The following is a description of a gene set: species: Homo sapiens Genes down-regulated in comparison of untreated CD4 T cells versus CD4 T cells treated with leukocyte costimulatory blockade antibodies. To elucidate the gene expression “footprint” of antigenically challenged T-cells which had been treated with anti-LFA-1, CTLA4Ig, anti-CD40-ligand antibodies, we performed microarray gene expression analysis comparing the expression profile of costimulatory blockade treated and untreated responder T-cells. from publication Pearl JI, Lee AS, Leveson-Gower DB, Sun N, Ghosh Z, Lan F, Ransohoff J, Negrin RS, Davis MM, Wu JC (PMID 21362570) Human Gene Set: GSE26669_CTRL_VS_COSTIM_BLOCK_MLR_CD4_TCELL_DN, and this is the list of marker genes: ST8SIA1, ARHGAP24, ATL1, FCRLA, MOSMO, RELL1, SCD, PTK2B, PRG4, TLE4, GGA2, ROGDI, ACP5, ABHD8, USP33, PRPS2, MBD4, ARF6, MTPAP, EOLA1, CROCC, CTU1, CABLES2, PRKCI, RC3H2, HMCES, RAP1B, ADD3, PDLIM7, RHOT1, CCDC71, SEMA3D, COQ8A, FAM3C, TES, ZBTB4, RIT1, EVI2B, HIBCH, MXI1, JUNB, ZNF799, PTGFRN, KIF1C, ADCY9, AXDND1, OARD1, SMC5, FPR3, LRRC42, PHF8, MAN1C1, TSC22D3, ATP6V0D1, EPC1, SIK3, CCN1, PDE2A, IQSEC1, MTIF3, LEF1, H2BC18, WDR26, SAA4, MBD1, CSNK1E, MTA3, RSPRY1, NINJ1, MTNAP1, FILIP1L, SGPL1, BMPR2, SETX, ERLIN2, NAA16, PEX12, ZNF771, TMC5, YPEL3, CCDC82, METTL27, DDX31, HAO2, ASNSD1, GID4 (NCBI Gene Id 79018), MAP3K5, CDR2, CCNY, CCR6, TTBK2, IER5, CYTH4, FOXJ2, GABRR2, TTC36, COLEC12, PCYOX1, SSMEM1, TMEM74B, CLCA1, RFFL, MZB1, RETREG3, BCL11A, CHIC2, ST8SIA6, MEX3B, RPS6KB1, TRIM32, RB1, CLPX, SEPHS2, AIM2, CDK14, SH2D1A (NCBI Gene Id 4068), SLC30A1, RNF103, THAP12, CATSPERG, HEY1, WWOX, HBB (NCBI Gene Id 3043), TBC1D5, RGL1, ANKMY2, IKBIP, CALCRL, PITHD1, SLC49A4, MFNG, MRPL22, PRKCB, SAP30 (Sin3A associated protein 30), DTX2, FXYD5, ALKBH5, RAMP1, ULK3, UFL1, SCARNA13, PRMT2, SQOR, MESD, SATB1, RNF128, FNBP1, SLF2, NFKBIE, ITGA4, KIAA0930, ACAD8, MCUR1, GPR137B, ASB7, ZMYM5, TGDS, FABP4, TBATA, TSHZ1, N4BP2, TAB3, SUN2, ICAM2, RASSF2, YPEL1, F8A1, PLPP3, HAVCR1, SCARB2, RAB11FIP4, SEC11A, TUSC1, TFAM, ZNF664, RWDD2A, CD27, LNPEP, SH3BGRL2, GTF3C2, ZC3H4, PXYLP1, S1PR1, TEX10, PLEKHO1, GPR183, JAK1, WNT10A, STT3B, UBIAD1, MAN1A2, H2BC3, YY1, LYL1, LMO4, NCOA1, STYX, PHGR1, WAPL, APOBEC1